The following is a description of a gene set: RND3 (RHOE) is an atypical RHO GTPase from the RND subfamily. RND3 is constitutively bound to GTP and lacks GTPase activity. No guanine nucleotide exchange factors (GEFs), GTPase activator proteins (GAPs) or guanine nucleotide dissociation inhibitors (GDIs) act on RND3. RND3 is a direct antagonist of ROCK1 kinase activity. RND3 prevents phosphorylation of ROCK1 targets and, similar to RND1, induces stress fiber disassembly. RND3 regulates cell migration, establishment of neuronal polarity, heart development, and myometrium changes during pregnancy. Defective RND3 function is related to cardiomyopathy, hydrocephalus and cancer. Like RND1, RND3 is implicated both as a tumor suppressor and an oncogene in cancer, and can both increase and decrease sensitivity to chemotherapeutic agents, which depends on cancer type and stage. For review, please refer to Jie et al. 2015 and Paysan et al. 2016. Reactome Pathway: RND3 GTPase cycle part of: RHO GTPase cycle species: Homo sapiens, and this is the list of marker genes: PTPN13, KTN1, CKB, CAV1, DSP, EPHA2, NISCH, PLEKHG5, RASAL2, ARHGAP21, CKAP4, TXNL1, VANGL1, CCDC88A, UBXN11, DEPDC1B, FLOT2, LEMD3, DLG5, DSG1, VANGL2, CPD, PICALM, PIK3R1, ARHGAP5, KCTD13, PKP4, TNFAIP1, ROCK1, ANKRD26, WDR6, FAM83B, MUC13, ARHGAP35, PIK3R2, DDX4, SEMA4F, DST, SCRIB, RBMX, RND3, TMOD3